Given this list of marker genes UMOD, AQP2, PKD2, NTRK1, PKD2L1, SIPA1, AVPR1A, ATP2B4, COL18A1, LRP11, PLEC, PIK3CA, here is a description of the gene set: Any process that results in a change in state or activity of a cell or an organism (in terms of movement, secretion, enzyme production, gene expression, etc.) as a result of a stimulus reflecting the presence, absence, or concentration of water. studied in species Homo sapiens Human Gene Set: GOBP_RESPONSE_TO_WATER